Given this list of marker genes Slc9b2, Slc9a7, Slc38a5, Slc9a5, Slc9a4, Slc9a2, Slc38a3, Slc9c1, Slc9a9, Slc9a8, Chp1, Slc9a6, Slc9a3, Slc9a1, here is a description of the gene set: studied in species Mus musculus Enables the transfer of a solute or solutes from one side of a membrane to the other according to the reaction: Na+(out) + H+(in) = Na+(in) + H+(out). Mouse Gene Set: GOMF_SODIUM_PROTON_ANTIPORTER_ACTIVITY